Given this list of marker genes PSMC5, PSMD13, PSMA6, UBE2D2, PSMD4, PSME2, PSMC4, PSMD10, PSMD7, PSMB7 (proteasome 20S subunit beta 7), PSMA1, PSMB5, PSMD2, PSMB3, PSMA2, PSMA5, PSMC1, UBE2D3, PSMB2, PSMD12, PSMD9, PSMA7, PSMD14, PSMC2, PSMD3, PSMA4, PSMA3, PSMD6, PSMD1, PSMB6, PSMC6, PSMB1, H2AZ1, PSMB4, PSME1, PSMD11 (proteasome 26S subunit, non-ATPase 11), PSMD8 (NCBI Gene Id 5714), here is a description of the gene set: species: Homo sapiens Proteasome. Human Gene Set: MODULE_91